Given this list of marker genes RGS13, CXCL5, DCT, ADGRG6, ENPEP, SRY, TRIB2, STRN, JUN, AFF2, SAA4, RRAGD, OMG, BLNK, REEP5, GALNT10, PHTF2, GUCY2C, PLCB4, KPNA6, CD58, SELL, ZC2HC1A, TYRP1, PLPP1, FLT1, LCP2, CYLC2, SUSD6, ADTRP, CSF1R, DZIP3, SAR1A, CD8B, LYZ, S1PR1, MAGEA1, ATG5, MCM2, DIXDC1 (NCBI Gene Id 85458), SLC39A8, TNNI3, ABHD5, PARM1, AGPAT1, ARSB, PRR4 (NCBI Gene Id 11272), APCS, F5, MTTP, CRIPTO, SPINT2, SMIM10L1, KHDRBS3, SREBF2, RGS16, CALD1, PLPPR4, P2RY14, CST7, SLA, IL10RA, CD47, UGT2B11, CD8A, VCAN, DKK1, ELAVL4, ZNF20, SPIN2A, AMIGO2, SOCS1, KCNA3, NUP58, TRPC6, TRPC1, KIF11, ZFR2, SHOX2, MBTPS2, CRTAM, SMPDL3A (NCBI Gene Id 10924), ZNF460, PALLD, ZNF208, DYNLT1, BCL2L11, SLC17A1, TEAD4, BUB1, KCTD12, TBC1D2B, SPICE1, MED13, HBP1, SEMA3C, ACD, SOS2, TP53BP2, PDK4, AFP, POLA1, ALDH3B1, SSX2IP, BMP2, PGAM2, MAP3K14, ZFP69B, H4C9, HBEGF, DSG1, RNF144A, IL1RN, CNGA1, RASGRP1, SNX7, RHOQ (NCBI Gene Id 56679), SYT1, S100A11, FARP1, CLDN8, MAP7, GC, PEMT, UPP1, EVI2B, ZIC3, MNAT1, KCTD17, IGKV1D-13, KRTAP26-1, CASK, KCNS3 (potassium voltage-gated channel modifier subfamily S member 3), COL3A1, MB, CHD3, CCRL2, PTPRO, DBN1, PCSK5, SLC22A4, MYO1B, PTPN4, SIRPB1, BCLAF3, HSF2BP, ST8SIA5 (ST8 alpha-N-acetyl-neuraminide alpha-2,8-sialyltransferase 5), KRT34, ATP7B, GPR183, MGP, ATP6V1H, BMP3, FPR3, PTPRN2, ATP7A, HMGB3, KLRG1, LRRN3, BTF3P12 (basic transcription factor 3 pseudogene 12), VPS9D1, RPS12, FUT9, GIT2, BCL6, ESR2, NFIL3, TNFAIP6, LCT, CNTNAP2, RGL1, CNTN5, DNTTIP2, H2BC21, IFNA14, SLC19A2, CPE, RSAD2, ALB, GUCY1A2, CTSL, STATH, SERPINC1, ATP6V1B1, GNAT2, MMP7, PTGIR (prostaglandin I2 receptor), SEMG1, ERG28, LRCH1, ACP2, KDSR, IFNA16, CHST10, POU3F4, MS4A3 (membrane spanning 4-domains A3), GGCX, KIAA1549L, here is a description of the gene set: Genes up-regulated in BCL6 high follicular helper T cells versus T conv cells. studied in species Homo sapiens We found that a number of Tfh cells downmodulated BCL6 protein after their development, and we sought to compare the gene expression between BCL6-hi Tfh cells and BCL6-low Tfh cells. from publication Kitano M, Moriyama S, Ando Y, Hikida M, Mori Y, Kurosaki T, Okada T (PMID 21636294) Human Gene Set: GSE24574_BCL6_HIGH_TFH_VS_TCONV_CD4_TCELL_UP